The following is a description of a gene set: Mouse Gene Set: GOBP_RETINAL_ROD_CELL_DEVELOPMENT studied in species Mus musculus Development of a rod cell, one of the sensory cells in the eye that reacts to the presence of light. Rod cells contain the photopigment rhodopsin or porphyropsin and are responsible for vision in dim light., and this is the list of marker genes: Nrl, Bhlhe23, Bbs4, Ntrk2, Samd7, Rpgrip1l (NCBI Gene Id 73313), Rp1, Alms1, Ahi1, Samd11, Miat, Cfh, Trpm1, Rorb, Naglu, Rpgrip1